Given this list of marker genes LRRTM3, LMO4, EPOR, ERICH4, WASHC3, AFG1L, CEP57L1, NHLRC2, HOXC8, ATG16L1, MED17, FABP3, B4GALT4, XPO7, SYS1, TSC22D4, ETS2, MAP3K7, TBCA, HSPE1, ZBTB41, ABHD18, ATG4A, UBA3, TNS2 (tensin 2), SEMA3D, SULT6B1, WFDC13, KCNJ5-AS1, TMX4, GPBP1, SMAD9 (NCBI Gene Id 4093), CASP1, AASDHPPT, EPCIP, ACAN, ENSG00000273590, HPS5, YIPF6, C1RL, PGC, KL, RELCH, TMCO4, BAIAP2L1, TFE3, LRRC55, MOG, VPS4B, BOLL, SLC2A13, RECK, BRPF3, NIBAN1, HOOK3, LUC7L2, F9, ANTXR2, CHUK, ASAH2B, FRYL, GSTA3, TRDN, ISL2, IFI44, EPS15, SLC2A11, JPH1, CHCHD3, FXN, HNMT, MYOZ3, C7orf57, GGT6, ZKSCAN8, SMIM11, ISCU, CDC14A, BUB1B, ATP5IF1, KLF17, FAT4, BCO1, COL12A1, C5orf34, METTL17, EIF4A2, PHACTR2, MYO1B, BRD3, GPATCH2L, SLC26A7, CCR1, GABPA, NEGR1, REG1A, TNN, MRS2, VGLL1, KCNB1 (potassium voltage-gated channel subfamily B member 1), GRB2, TSPO2, TMPRSS15, CA1, TAOK3, BMP3, PWWP2A, PSMA1, IL17D, JMY, TMEM41B, TDO2, ADH4, SPATA6, FRK, LIN9, ADCYAP1, PPP3CA, A2ML1, USP14, GMPPB, CMSS1, HMCN1, LCE2C, ALS2, TMEM70, LDLRAD2, NOX1, CISH, MTAP, TNFAIP2, GSK3B, CALHM3, CCDC32, FBXO25, DDX21, FABP4, MMAA (NCBI Gene Id 166785), JARID2, LARP6, STK17B, L3MBTL4, C8orf34, PRKD1, DLK1 (NCBI Gene Id 8788), ANKDD1A, MARCHF3, ARL5A, CLCC1, ZFR, CORO2A, ZNF33B, YIPF5, ZNF777, TMX1, CEACAM1, SLC25A30, SRFBP1, EFCAB5, KMT5A, TLCD4, CASK, KCNH2, CERS6, RORA, MIA2, ARID2, HERC3, GRM8, ZNF695, AGTR2, CTR9, EPHA5, CD84, DTL, RGS20, SAE1, GATA3, TMPO, ODAPH, PGBD1, CALHM1, WWC1, NETO1, USP45, TCIM, BRWD3, M1AP, HOXB6, TMEM182, PREX2, MINAR1, TGFBI, NXF2B, FUT9, AHR, NCOA7, GRIK1, RASAL2, RGS10, COBLL1, EXD2, VPS35, NAT1, POGLUT2, CADM2, FRZB, STEAP2, TMEM33, XIRP2, PKHD1, FZD2, SLC16A7, MBOAT1, MBP, CHURC1, NDUFS1, GOSR1, PRKX, AKAP13, HSFX3, SLC16A9, HOXB5, PTPN4, CCP110, TCTN1, ZNF567, FNTB, HOXA13, GLS, PNN, EXOSC9 (NCBI Gene Id 5393), ARK2N, SMCHD1, ZNF74, MEF2D, FBXO6, PTGS2, MCHR2, SLC27A6, ST8SIA3, RP2, ARMC1, QPRT, GJA3, UTRN, SRD5A3, NCAN, GLRB, OLFM3, FPGT (NCBI Gene Id 8790), SGPP1, LTN1, ZBTB20, MYD88, CCSER1, VCPIP1, WDR64, NFKB1, MAN1A1, LMBRD2, C17orf75 (chromosome 17 open reading frame 75), CRIPT, SRSF12, CASP3, CAMK2A, MED11, EPGN, ESRRG, PCDH7, CNOT4, ANXA8L1, AP3B1, SESN1, EBF1, SPOUT1, RFTN2, STAM2, ERGIC2, AIG1, GK, IL15, DUSP28, DCDC2, DERA, COA8, BTLA, TEX14, NRAP, ZBTB8B, SYT10, TUBGCP4, CHEK1, ENSG00000277067, TBC1D9B, UBE2W, TMEM170B, MR1, USP12, ZFC3H1, LCE2B, NWD1, CCDC186, NFAT5, KRCC1, HPN, AMFR, CPSF7, TBX3, ACVR2A, ABCA5, EFR3A, RSBN1, CSF2RA, EREG, MLANA, PRPF8, FGD2, MBLAC2, GSDMC, SHISA3, MACC1, FRMPD4, WDR35, CLEC12B, MBTD1, GLE1 (NCBI Gene Id 8012), NUP133, C3orf80, SLC49A4, PEX5L, ABI1, VPS13A, CLEC1A, AMACR (NCBI Gene Id 23600), CCDC14, LPP, TCHH, DTD1, APPL1, CDK13, SETD9 (NCBI Gene Id 133383), AKR1B10, ABCD3, HSD11B1, TRPS1, KMT2A, SNRPN, GNB5, POFUT1, FMC1-LUC7L2, AKAP4, ZIC2, HBS1L, LAS1L, ZNF211, FGF12, HGF, VEZF1, TET1, CFHR4, BLZF1, ARSK, CELF2, FAM216B, CALCB, KIRREL1 (kirre like nephrin family adhesion molecule 1), NUP43, ONECUT2, NIPA2, MYBL1, SH2D1A, SLC7A14, HSPB8, IFFO1, DAP3, FGG, NOLC1, ELAVL4, TMTC1, SNURF, MDGA2, ZNF432 (zinc finger protein 432), RABL3, METTL25, TCEAL9, CCDC149, DYNLT3, IL17A, NPAS2, MSRB3, C11orf87, SHISAL1, SPAST, ZNF346, TRIP6, SLFN13, CEPT1 (choline/ethanolamine phosphotransferase 1), MXRA5, REPS2, SEMA6D, NFXL1, SGK3, DOCK7, DNAH14, GARRE1, MME, TMEM266, NUFIP2, PDZD8, ASTN1, SPATA18, TRMT10A, MAP9, TRAF6, HMOX1, RWDD4, GNE, ANTXR1, ANGPT1, RALGPS1, COQ9, GPR137B, RXRG, VPS13C, RGPD4 (RANBP2 like and GRIP domain containing 4), RFX4, RGPD6, MMS22L (NCBI Gene Id 253714, MMS22 like, DNA repair protein), ZDHHC15, TRIM8, UBE2V2, PATE1, TNC, MOCS2, EGFL6, DBNDD2, CACNA1A, KLHL7, MAP3K2, UBE3C, L2HGDH, BICD2, KDM6A, S1PR3, RAB30, TCEANC2, MAT2B, FBRSL1, RTN4RL1, SLCO1A2, ZNF639, DENND1B, CNTNAP2, PPDPFL, EPHA7, PCDH11Y, ANO2, FAM78A, MAGEB5, SYNPO2, RGPD5, IKZF2, TRPC5 (NCBI Gene Id 7224), CCDC25, SHH, MFAP4, LINC03104, ZBTB21, ATP8B1, C2CD4A (NCBI Gene Id 145741), PPP1R12B, NPAT, ANKRD42, WIPI1, SETD5, IVD, NXF2, ARHGEF38, C9orf153, SERPINE1, SEPTIN7, SEPSECS, RGR, PPP4R3A, NR1D2, ZNF703, GUCY1A2, PLXNA4, ANXA8, BDH2, SLC6A15, GLYAT, ENPP2, BDNF, SNCA, SELENOI, PDE7B, NACC2 (NACC family member 2), BCAP29, PEX13, CFAP91, CFAP299, SPATA2, MRPL13, DYRK2, NPTXR, FMN2, TMEM216, COL11A1, PAX2, IL36G, RANBP3L, FAP, MEX3A, ANK3, GRIK2, LINC03105, CXorf38, NCK1, NLGN4X, COMMD2, DIO3 (NCBI Gene Id 1735), CHRNA5, CSF1, PPIL6, C21orf91, UBLCP1, MDM4, CCDC13, FGF7, PPBP, SLC25A53, TCAIM, CIAO2A, ZNF135, CHST11, ZNF224, CAVIN2, TRADD, SGCB, HYDIN, ETV1, RSPO3, SFRP4, IL7, SSBP3, RO60, GABRB2, UGT8, KHDRBS2, INPP5D, EIF4A3, NSL1, LRRC74B, ATXN1L, RABGEF1, CADM1, NCAPH, IL11, CASP9, MMP20, CDK20, TET2, GABRA5, ZNF208, CCL28, GARIN3, CYP1B1, ADHFE1, EDA2R, SUPT3H, CDC5L, PPARGC1A, UNC5D, TFEC, LRFN4, ARID1A, TMPRSS13, LACTB2, ALDH1L2, CTDSPL2, BLTP1, NXF5, ZDHHC20, FAM13B, NALF1, SLC20A2, PPIF, OSTF1, VWA8, IL1F10, AFF4, TOB1, CDH7 (cadherin 7), DNAJC1, EEF1AKMT2, ZFAND5, TNFAIP8L3, TSHZ3, MUC17, LAMTOR3, SETBP1, MID1IP1, BRAT1, KCNT2, GABRA4, PDZRN4, THAP3, GABRA1, MAPK10 (mitogen-activated protein kinase 10), SH3BGRL2, ELAVL2, NEUROD6, CNTN1, GUCY1A1, ATG7, LACC1, BIRC6, TMEM100, TYRP1, PPAT, ST6GALNAC5, PPFIA2, SPATA4, RIMS1, ODR4, GTF2F1, MRPL57, DNAJB9, FCHO2, PI15, CYS1, CFHR3, DBF4, TECPR2, RASSF6, ANKRD29, KLHL9, TMED5, FBN2, PPP1R10, HECA, ZBTB7C, RPSA, DYM, KIAA1549L, OCLN, DLG1, DCAF13, KCNN3, ZNF148, QRSL1, CDCA7, CHD1L, FYB1, MSR1, C6orf136, SLC7A4, REP15, MGAT3, TNFAIP3, ZFHX3, CAMK4, FAM111A, FBN1, ARL11, STC1, MIPOL1 (NCBI Gene Id 8107), VWC2, ERVV-1, PDLIM5, SLC45A1, FNIP2, HOMEZ, MMRN1, GLIPR1, IDS, PTPN12, PIAS2, DCLK1, PNLIPRP3, ATP1A2, PPIL1, SOX6, PTPN20, PNRC1, RGPD8, AOPEP, SPRY4, MAK, ESRP1, ACVR2B (NCBI Gene Id 93), ARSJ, AMMECR1L, EPHB1, KLHL41, SYNJ2BP, CREB5, CHST7, GRM5, ADAMTS6, NFIA, IGBP1, TMEM19, PCDH11X, CHMP5, FLT4, ATG3, SAMSN1, REG3G, ESCO1, HECTD2, PTPRD, ARMT1, GFRAL, LINGO1, RINL, SCRN1, FAM168A, ADAMTS4, TRMT9B, ZNF333 (NCBI Gene Id 84449), MDH1, KCNMA1, GOLGB1, GIMAP8, ZIC5, here is a description of the gene set: Genes predicted to be targets of miRBase v22 microRNA hsa-miR-4795-3p in miRDB v6.0 with MirTarget v4 prediction scores > 80 (high confidence targets). studied in species Homo sapiens from publication Chen Y, Wang X (PMID 31504780) Human Gene Set: MIR4795_3P